The following is a description of a gene set: Genes predicting the teratoma (T) subtype of nonseminomatous male germ cell tumors (NSGCT). Male adult germ cell tumors (GCTs) comprise two major histologic groups: seminomas and nonseminomas. Nonseminomatous GCTs (NSGCTs) can be further divided into embryonal carcinoma (EC), teratoma (T), yolk sac tumor (YS), and choriocarcinoma (CC) on the basis of the lineage differentiation that they exhibit. NSGCTs frequently present as mixed tumors consisting of two or more histological subtypes, often limiting correlative studies of clinical and molecular features to histology. We sought to develop a molecular classifier that could predict the predominant histologic subtype within mixed NSGCT tumor samples. The expression profiles of 84 NSGCTs (42 pure and 42 mixed) and normal age-matched testes were obtained using Affymetrix microarrays. Using prediction analysis for microarrays, we identified 146 transcripts that classified the histology of pure NSGCTs samples with 93% accuracy. When applied to mixed NSGCTs, the classifier predicted a histology that was consistent with one of the reported components in 93% of cases. Among the predictive transcripts were CGB (high in CC), LCN2 (high in T), BMP2 (high in YS), and POU5F1 (high in EC). Thus, the expression-based classifier accurately assigned a single predominant histology to mixed NSGCTs, and identified transcripts differentially expressed between histologic components with relevance to NSGCT differentiation. Human Gene Set: KORKOLA_TERATOMA from publication Korkola JE, Houldsworth J, Dobrzynski D, Olshen AB, Reuter VE, Bosl GJ, Chaganti RS (PMID 15870693) studied in species Homo sapiens, and this is the list of marker genes: LCN2, CCNB1, TRIM71, ZFP36, LIN28A, AURKA, DLGAP5, DCN (decorin, NCBI Gene Id 1634), ELN, MRS2, HIC2, AGR2 (anterior gradient 2, protein disulphide isomerase family member), JUN, CKS2, NUF2, MCM5 (NCBI Gene Id 4174), MBD2, TSPAN8, PLAT, DPPA3 (NCBI Gene Id 359787), MIR302D, EPS8, LRRC17, FAM72C (NCBI Gene Id 554282), TM4SF1, EMP1, EHF, DNMT3B, NFKBIZ, SSPN, CLDN6, COL14A1, CLIC6, CDC20, FEN1, PIGR, CENPA, MYCN, MFAP4, MGP, ZWINT, EGR1